The following is a description of a gene set: A process in which a series of electron carriers operate together to transfer electrons from donors to any of several different terminal electron acceptors. Mouse Gene Set: GOBP_ELECTRON_TRANSPORT_CHAIN species: Mus musculus, and this is the list of marker genes: Cox5a, Park7, Ppargc1a, Bdnf, Cdk1, Cox8a, Thap11, mt-Co1, Sco2, Cox6a2 (NCBI Gene Id 12862), Ndufb6, Tafazzin, Gba1, Snca, Mybbp1a, Ndor1, Mir451a, Aifm1, Ndufa5, Wdr93, Cox7b (cytochrome c oxidase subunit 7B), Uqcrb, mt-Nd6, Cox7a1, Afg1l, Cox5b, Chchd2, Cox8b, Ccnb1, Cox4i1, Cox7a2, Cox7a2l, mt-Nd4, Ndufv1, Uqcr10, Uqcrc1, Uqcrfs1, Etfa, mt-Nd2, Sdhd, Sdha, Ndufaf1, Pum2, Cox6a1, Cox7b2, Vps54, Etfb, Cyc1, Ndufs7, Etfrf1, mt-Cytb, Mir451b, mt-Nd1, Pink1, Cox4i2, Pm20d1, Fdx2 (NCBI Gene Id 68165), Ndufv3, mt-Co2, Norad, Etfdh, mt-Co3, mt-Nd4l, Bid (BH3 interacting domain death agonist), mt-Nd5, Ndufc2, Por, Slc25a51, Chchd2-ps, Ndufa10, Uqcrc2, Coq7, Coq9, Plec, Uqcc3, Ndufs8, Sdhb, Cycs, Ndufb8, Ndufs4, Iscu, Ndufs6, Ndufs2, Sod2, Ndufa11 (NCBI Gene Id 69875), Dhrs2, Mtch2, Ndufs3, Aifm2, Ndufs1, Cox8c, Ndufa7, Immp2l, Dguok, Ndufb9, Ndufa12, Uqcrh, Cox7c, Enox2 (ecto-NOX disulfide-thiol exchanger 2), Uqcr11, Sdhaf2, Uqcrq, Fdx1, Cyct, Ndufb3, Dnajc15, Ndufv2, mt-Nd3, Coa6, Ccnb1-ps, Hoxb3os, Ndufa8, Sdhc, Dld